The following is a description of a gene set: Mouse Gene Set: GOBP_PROTEIN_DNA_COMPLEX_ORGANIZATION Any process in which macromolecules aggregate, disaggregate, or are modified, resulting in the formation, disassembly, or alteration of a protein-DNA complex. studied in species Mus musculus, and this is the list of marker genes: H2ac25, Cenpc1, Smarca5, Baz1a, Med21, Bdp1, Med11, Kntc1, Macroh2a1, Nap1l1, Med8, Mcmdc2, Med6, H1f4, Cenpv, Ttc39aos1, Mcm3ap, Tspyl4, Rrn3, Supt16, Med24, Arid2, Smarcc2, Lin54, Cenph, Shprh, Tbp, Cenpx, Daxx, H1f9, Taf6l, Sart3, Med4, Brd2, H1f8, Cdt1, Gmnn, H1f6, Rnf4, Itgb3bp, Brf1, Chd1, Ep300, Creb1, Rsf1, Med23, Med9, Oip5, Pias1, Rad52, Pogz, Mis18a, Med20, Kat6a, Naa60, Anp32b, Med31, Hmgb1, Nap1l4, Spty2d1, Chaf1b, Med14, Chd2, Trp53, Rpl23, H3f3b, Med17, Sugt1, Setd2, Med19, Rbbp4, Kat6b, H3f3c, Cenpp, H1f1, Nap1l5, Taf6 (NCBI Gene Id 21343), Tcf4, Taf10, Med1, Cenpo, Ikzf1, Cdc45, Smarcd2, Tnp1, Pole3, H4c14, Taf8, Psmc6, Smarcd3, Arid1a, Ssrp1, Hey2, Cenpa, Hjurp, H2bc1, Dlgap5, Polr1e, Med27, Macroh2a2, Med26, Trappc12, H1f3, Hira, H2al2a, Hnf1b, Taf7, Supt6, Atad2b, Taf11, Nap1l3, Smarcd1, Ubn1, Cenpk, Med29, Cenpn, Taf1, Npm1, Tspyl1, Cenpw, Nfkbiz, Smarca4, Gtf2h5, Cebpg, Med10, Taf1b, Med16, Med22, Tspyl2, Smyd3, Med7, Smarca2, Cenpt, Gtf2a1, Med30, Nasp, Taf3, Wnt10b, Taf5, Thra, Gtf2b, Cand1, Brf2, Taf4 (NCBI Gene Id 98977), Smarce1, Taf4b, Taf2, Set, Bmyc, Nap1l2, Sox9, Dmc1, Cenpi, Smarcc1, H1f5, H1f0, Gtf2a2, Padi4, Ahr, Taf13, Terf1, Taf12, Atrx, Chaf1a, Grwd1, Mis12, Cenpe, Senp6, H1f2, Med18, Hp1bp3, Dr1, Atad2, Taf7l, Gtf2f2, Med25, Asf1a (NCBI Gene Id 97642), Asf1b, Tspyl5, Taf1c, Med15, Zfp827, Med28, Rad51, Taf9, Smarcb1, Mcm2, Dnajc9, Myc, Esr1, Chrac1, Rad51c (NCBI Gene Id 114714)